Given this list of marker genes LRTM2, CYTH4, KDM2A, PGAP2, PFN1, CYSLTR1, LRRC55 (leucine rich repeat containing 55), MFSD8, TLE1, RNF121, UTP3, LDB1, MSANTD2, NEK7, DCP1A, LRRC41 (leucine rich repeat containing 41), HMGB1, DIP2B, SMARCD1, MXI1, SH3PXD2A, MAP3K19, AP1G1, ZNF346, MND1, AJAP1, NFASC, TCF12, C11orf87, RNF38, KIF7, RAVER1, PLOD2, ZNF746, KCNMA1, CREBZF, SWT1, CLEC12A, SYCE2, FAM161B, CMTR1, PATJ, HECTD4, SPCS2, TNPO2, RNF7, STXBP5L, NFKBID, TBCK, ANP32A (NCBI Gene Id 8125), HKDC1, SMARCA1, PEX5L, STAB1, IL31RA, EIF2A, SRSF2, CPT1A (NCBI Gene Id 1374), MEIS2, SUMO3, UVRAG, CHD3, MFHAS1, GTPBP10 (GTP binding protein 10), here is a description of the gene set: Human Gene Set: MIR7155_3P Genes predicted to be targets of miRBase v22 microRNA hsa-miR-7155-3p in miRDB v6.0 with MirTarget v4 prediction scores > 80 (high confidence targets). species: Homo sapiens from publication Chen Y, Wang X (PMID 31504780)